Given this list of marker genes UBE3A, SLC38A3, FKBP8, MAPRE3, PLAC1, IL6, TAGLN2, ARRDC4, MPRIP, BUD31, PIANP, MAP2, PDAP1, TOB1, S100A5, LPP, PKN3, NPY, HPSE2, AKT1S1, IL9, BLVRB, FEZF2, LMNA, SLC4A11, KDM3A, FARP1, CLUH, AKAP1 (A-kinase anchoring protein 1), FLI1, PPP2CA, PORCN (porcupine O-acyltransferase), COL27A1, KCNN4, LAPTM5, RPL23, ZNFX1, MAPK3, S100A2, RGS8, GABBR1, ATP6V1A, PSMD11, DUSP13B, TMEM156, KRT8P41, CYFIP1, PLEKHH3, LYVE1 (NCBI Gene Id 82367), TCEAL9, CYP24A1, EEF1A1, KLHL1, EPB41L1, RUNDC3A, SYTL1 (NCBI Gene Id 84958), LTBP3, SMARCA2, MDFI, MMP19, CAMKK1, SDCBP, MINK1, SV2A, TENM3-AS1, SYNPO, SHC3, PPP1R9B, LRRC3B, STOML2, GSN, CRYGS, STK40, ST18, NECAB3, CORO1C (coronin 1C), RIN1, NCDN, GABRA1, ZNF23 (NCBI Gene Id 91855), SGTB, RAPGEF6, NDP, FLNC, FOS, NAA50, ZNF516-DT, PAK6, KY, GAPDH, SLC6A9, FHL3, RELL2, ST8SIA5, GPR150, GNGT2, USP3, KCNK10, PCDH9, IRAK1, PTGES3 (NCBI Gene Id 10728), TBC1D17, RAB37, CILK1, GNAI1, RAB22A, RTN4, ROM1, PLBD2, PTPRH, AK5, MARCHF6, VGF, SCOC, GGN, VEGFD, TUBA1C, EEF1A2, CAPNS1, CLC (NCBI Gene Id 1178), SGIP1, BAZ2A, ZNF385B, DCHS1, MAP4, SNCB, PAX9, SMAP2, KCNH6, PSMA3, CLSTN3, UCN2, FGF11, LMTK2, CRK, HS3ST2, VDR, USP2, ZNF771, SLC35E4, DIAPH1, MMP7, JMJD1C, ETV5, DNAJB5, CCDC50, SLC9A5, ZPBP2, AGPAT1, PTPRN, S100A10, TEX19, KLHL40, MAP1A, HS3ST3B1, XIRP1, ORAI1, EML3, TRPV3, PAFAH1B1, PRKACA, NTRK2, CA9, AKT3, STX17, TRIM8, SLC20A1, CIZ1, FAM178B, PIM2 (Pim-2 proto-oncogene, serine/threonine kinase), TIAL1, FGF12, LRP1B, ASS1, HOXD9, ID1, REXO2, PITPNC1 (NCBI Gene Id 731962), SLC25A51, IGSF22, TSNAXIP1, BRAF, TRIP10, ATXN7L2, DSTN, SORT1, CASK, MAP2K1, AXIN2, PLPBP, PTPRR, FBXW11, PRDM1, XPOT, RAD23B, RGS6, CACNG2, DCN, TLE4, SARNP, NHS, RNF5, DNM1, CYTOR, SCRN1, ROCK2, IL23A, ANXA7, BLMH, GAB2, SRC, GRIN2D, CRYBA2, SPTA1, LAMC2, SPTBN4, MYBPH, CA7 (NCBI Gene Id 766, carbonic anhydrase 7), DDX17, VIM, RTN3, TMCC1, LAMC1, APOBEC1, TCF12, EPHA2, KLHL41, CACUL1, HDAC3 (NCBI Gene Id 8841), UBQLN1, DTX2, ZNF593, RNF144B, OMG (NCBI Gene Id 4974), PDGFRB, CMAS, EFNA1, CBLIF, TGFBR2, C1QTNF8, ITGB8, CALM3, HCFC1, PAPPA, GOLGA4, IL1RN, NRXN2, UBE2C, FHOD1, FLRT1 (fibronectin leucine rich transmembrane protein 1), USP13, SLC16A6, NRIP3, PLCD1, KBTBD8, CD244, EIF4G1, ATOH8, STAT5B, CMYA5, MEIS2, ABI3, IGFBP6, ISG20, NLN, GJB3, EIF3J, HOXA11, LAMB3 (NCBI Gene Id 3914), SIX4, CYP11A1, here is a description of the gene set: species: Homo sapiens Genes having at least one occurrence of the motif RSTGACTNMNW in the regions spanning 4 kb centered on their transcription starting sites. This matches the JUN transcription factor binding site V$AP1FJ_Q2 (v7.4 TRANSFAC). Human Gene Set: AP1FJ_Q2